Given this list of marker genes Lyrm1, Ccdc171, Gpm6a, Klhdc7a, Actl6a, Wasf1, Map7, Pgm1, Zfp36l1, Retreg3, Ccn3, Bmpr1a, Arfgef3, Dgkk, Mgat4c, Tspyl5, Dhx9, Rtn4rl1, Abcg4, Ube2l3, Ccr7, Lrba, Ramp2, Hlf, Cox11, Maf1, Ankib1, Papss1, Ppat, Bbs10, Zfhx3, Dnajc11, Iqschfp, Marf1, Schip1, Cdh11, B020004C17Rik, Slc35f1, 4930453N24Rik (NCBI Gene Id 67609), Paqr9, Cd200r3, Ppm1d, Map2k6, Slc41a3, Cdh10, here is a description of the gene set: from publication Chen Y, Wang X (PMID 31504780) Mouse Gene Set: MIR_6949_5P Genes predicted to be targets of miRBase v22 microRNA mmu_miR_6949_5p in miRDB v6.0 with MirTarget v4 prediction scores > 80 (high confidence targets). studied in species Mus musculus